The following is a description of a gene set: studied in species Homo sapiens Genes down-regulated in cancer stem cells derived from glyoblastoma tumors: CD133+ vs. CD133- cells. Human Gene Set: BEIER_GLIOMA_STEM_CELL_DN Although glioblastomas show the same histologic phenotype, biological hallmarks such as growth and differentiation properties vary considerably between individual cases. To investigate whether different subtypes of glioblastomas might originate from different cells of origin, we cultured tumor cells from 22 glioblastomas under medium conditions favoring the growth of neural and cancer stem cells (CSC). Secondary glioblastoma (n = 7)-derived cells did not show any growth in the medium used, suggesting the absence of neural stem cell-like tumor cells. In contrast, 11/15 primary glioblastomas contained a significant CD133(+) subpopulation that displayed neurosphere-like, nonadherent growth and asymmetrical cell divisions yielding cells expressing markers characteristic for all three neural lineages. Four of 15 cell lines derived from primary glioblastomas grew adherently in vitro and were driven by CD133(-) tumor cells that fulfilled stem cell criteria. Both subtypes were similarly tumorigenic in nude mice in vivo. Clinically, CD133(-) glioblastomas were characterized by a lower proliferation index, whereas glial fibrillary acidic protein staining was similar. GeneArray analysis revealed genes to be differentially expressed by these two subtypes. Together, our data provide first evidence that CD133(+) CSC maintain only a subset of primary glioblastomas. The remainder stems from previously unknown CD133(-) tumor cells with apparent stem cell-like properties but distinct molecular profiles and growth characteristics in vitro and in vivo. from publication Beier D, Hau P, Proescholdt M, Lohmeier A, Wischhusen J, Oefner PJ, Aigner L, Brawanski A, Bogdahn U, Beier CP (PMID 17483311), and this is the list of marker genes: RIOX2, CD74, BCL2L2, FBXO6, IFIT5, KIAA0930 (NCBI Gene Id 50610, KIAA0930), AZIN2, BTN2A2, BASP1, FTH1, HLA-DRA, LNX1, HBEGF, AMIGO1, HLA-DQA1 (NCBI Gene Id 7946), DDAH2, ECD, FAM167A, SOS2, IGFBP3, USP36, GLTP, EXOC6B, NFKBIZ, PORCN, PCNX4, LRCH2, HLA-DRB1, RNF112, GANC, MAPRE3, LAPTM5, HLA-DPA1, CUEDC1 (NCBI Gene Id 404093), DUSP3, SYNE3, GPNMB, TAF8, SNX21, INPP1, DTWD1, HLA-DMB, SUPT3H, TIMP2, LPIN1, MORN4, HLA-DQB1, TCEAL7, KLF7, YWHAB, GPN2, ZNF717, HIF1AN, MGLL (NCBI Gene Id 152009), FUCA1, EIF4E3, HNMT, NXPE3, CACNA1A, SLC11A2 (NCBI Gene Id 4891), HLA-DMA, CCND1 (NCBI Gene Id 893), TLE3, COMMD1, BMP2, FZD6